The following is a description of a gene set: Transcription regulation during the cell cycle is crucial for ensuring genes are expressed at the right time and in the correct amounts, coordinating key processes like DNA replication, mitosis, and cell division. In our study, Genes whose expression fluctuates during the cell cycle (pVal < 0.05) and peaks in G2/M (G2/M) in K562 Human Gene Set: PULVER_FOREY_CELLCYCLE_PEAKING_G2_M studied in species Homo sapiens, and this is the list of marker genes: RUSC2, KCTD2, CCDC57, CENPA, CYTH3, GAD1, RUVBL2, YIF1B, BRD8, PPP6R2, PYM1, RCOR1, FRAT2, NOL7, BCKDK (NCBI Gene Id 94996), UCKL1, NOB1, DCAF6, GAS2L3, LRRFIP2, PHF21A, MKNK1, MEX3A, USP19, PER1, CD55, EXOC7, NUDT13, AURKA, MAP3K10 (mitogen-activated protein kinase kinase kinase 10), ARRDC1, PPIP5K1, CCDC86, UBAC2, KDM8, CTNND1, PRPSAP1, DDX54, PGLS, FZR1, PCMTD2, FHL3, ENC1, HERC2, FCGR2A, HSPA6, SORT1, ECE2, FBXO31, FAM72B, TNFRSF12A, MYPOP, DPAGT1, TNNT1, GLG1, GALK1, RASA3, TESMIN, FPGS, GPSM2, RPUSD3, ATP8B4, ARVCF, ADGRE5, RXRB, MICALL1, RNF216, WDFY2, MTA1, HSD17B7, ERBB2, PDXK, EPS15L1, CAPN1, CCSAP, CHRNB1, AAR2, RRS1 (NCBI Gene Id 90810), SGPL1, REPIN1, HINT3, NFATC4, D2HGDH, PTPN23, TST, IRF2BPL, ZNF165, DGAT1, RCSD1, LRP10 (NCBI Gene Id 26020), ZMAT1, ATXN2, WEE1, ITPKC, TRIM5, AKR1C1, TGIF2, FAM43A, DLGAP5, UBTF (upstream binding transcription factor), IVD, MPV17L2, ARHGEF11, RAPGEF1, DIP2B, KRI1, TCEANC2, PSMD13, WDR46, THADA, PILRB, TNIK, GRIN2D, C6orf62, ARHGEF7, SLC2A14, UBE2O, FLOT1, AQP10, SIX5, CBX6, TMCO3, SYMPK, SNX9, GPR108 (G protein-coupled receptor 108), CSMD1, CCDC85C, ST7, ANKS1A, PRMT5, RUNX2, PRKD2, TNRC18, DPH2, NUDT2 (NCBI Gene Id 318), KLC2, HSPA1A, NR1D1, PHACTR1, RANGRF, HP1BP3, PHLDB3, KAT2A, PPP1R10, SNX29, GOT1, RANGAP1, SPDL1, PSMD3, MMACHC (NCBI Gene Id 25974), CCDC61, SLC2A3, IFT172, PITPNM1, TNFAIP8L1, TOMM34, CEP164, PEMT, ITGB5 (integrin subunit beta 5), KLF16, ESRRB, CMIP, KNSTRN, MEN1, ZNF783, PAK4, SCAP, HOOK2, NDE1, EEIG1, FAM53B, TMEM19, FAM110A, CSNK1G1, KDM4D, BCAT2, SLC26A2, DNAAF5, PARP3, SPHK2, ANXA7, MOGS, PTRH1, R3HDM4, NUTM2D, SERPINB6, NUDCD2, VSIG10L, AIM2, HDAC7, CBL, TSKS, FCSK, CSNK1E, HSPA1B, SUFU, AGPAT3, KATNA1, PFKFB4, CDC42EP2, PAFAH2, CDIPT, KCNH4, PPARD, CLDN11, NCBP2, TBC1D22A, HAX1, DEPDC1, IFT140, JARID2, RNF169, PSRC1, ACAD10, ALG3, AGAP1, DTX2, INTS3, DDX10, CEP70, MAVS, ZNF593, FTSJ1, PLK1, CTSH, PPFIA3, SGO2, UBL7 (NCBI Gene Id 84993), DHX34, SNAI3, TP53BP1, UBE2R2, CEP44, PDE4A, FAM118A, AIMP2, RPS6KA4 (ribosomal protein S6 kinase A4), FIS1, MRPL4, ERF, NRXN2, GRAMD4, CDYL (chromodomain Y like), FADS1, YTHDC1, MAPKAPK3, USP36, LRWD1, PABPN1, FLNB, ERCC2, IPO13, ZSCAN5A, CD59, TSSC4, MIGA2, CR1, TRIB2, PHF23, TRIM47, UBALD2, ZMIZ2, CKAP5, CLUH, KDM4B, CDAN1, MAN1B1, SOX12, CDK19, DELE1, PPM1H, SLCO2B1, GID4, CDC42BPA, KCNJ8, PPP2R5D, AKIRIN2, MVK, MRPS26, ARHGAP21, TRIM59, ZNF48, VANGL1, ZSCAN2, CCDC120, HERPUD2, SNX1, MICA (MHC class I polypeptide-related sequence A), TRIP6, YDJC (YdjC chitooligosaccharide deacetylase homolog), EMC9, TBX1 (NCBI Gene Id 7413), DCTN1, QTRT1, AGTRAP, FCRLB, MCRIP2, PTGES2, ACTR1A (NCBI Gene Id 10121), AP2A2, RNH1, CNNM2, RAB31, UBE2G1 (ubiquitin conjugating enzyme E2 G1), CACNA1I, NLK, RGP1, PPP1R11, CENPE, MIF4GD, SLC45A4, STON2, TACC3, MVD, NOS3 (NCBI Gene Id 4846), PKN1, PRICKLE3, KDM2A, TRIM4, NEK2, TSC2, ARHGEF39, ITGA5, PWWP3A (NCBI Gene Id 84939), SIGIRR, TMUB2, FBXO6, TEAD2, ZSWIM4, STK17B, ACSS2, EFNA4, PNKD, DNAAF2, KCNH2, CARD8, NACC2, IER5L, HMG20B, ATP8B3, PPP2R5A, KIF4B, WBP2, ANKIB1, DAPK2 (death associated protein kinase 2), MAPKAPK2, SMARCAL1, APOL4, ATG4B, KRT18, PMVK, BRMS1, OTUB1, VASP, HMGB3, RP9, NRROS, SNX33, MAX, KIF14, ERG28, GBA1, ZBTB22, NCAPD2, RAP2B, TNIP1, G6PD, MED12, MITF, C8orf82, PIAS3, KIF4A, FURIN (furin, paired basic amino acid cleaving enzyme), TKFC, NEU1, MID1, IQSEC2, DVL1, FBH1, EIPR1, LMTK3, POLR3H, AMIGO2, JPT1, HSPG2, FOXJ2, AFG1L, NEURL1B, HMMR, COMMD7, FAM3A, RCC1, GTSE1, SETDB2, PTTG1IP, SLC27A4, FZD2, BAZ2A, ADO, MLXIP, SURF4, STIM1, YWHAG (tyrosine 3-monooxygenase/tryptophan 5-monooxygenase activation protein gamma), TANGO6, CLCN5, CCNF, CALM2 (calmodulin 2), PQBP1, CDK2AP2, BCL2L13, POR, CCDC134, G6PC3, TBC1D25, MRTFA (NCBI Gene Id 89880), SAPCD2, EHD1, HIF1AN, PLA2G3, DYNC2I1, FLYWCH1, NABP2, CCNB1, CTBP1, DEXI, NECTIN2, CASP8, RNF5, SMTN, GRK6, ZDHHC18, OPLAH, PKP3, NOA1, RUSF1, MPST, VPS37B, EPHB6, TUBA1C, SOX15, TRIM41, MUC19, SLC39A11, ZNF296, RFX5, HEY1, PIMREG, BRF1, ISYNA1, NARF, LZTR1, RAB4A, AJUBA, ARID5B, ACY1, HNRNPA0, DNM2, UBE2S, MAP2K2, TFE3, PYCR1, B9D1, PTPN9, ZNF3, NECAP2, SHKBP1, DCAF8, SAMD4A, PCGF3, TMEM184B, ANTXR2, SRF, NDST1, RSAD1, ATP2B4, ARL6IP1, INTS15, PRKCB, RFNG, INO80B, PARD3B, POLL (DNA polymerase lambda), SKI, KIF26B, GAK, MAPKAP1, FAM83G, SLC11A1, ANK3, FGF5, POMT2, TRIM27, POLG2, NCOA3, EML3, GRB10, ATF6B, FAM117A, TRAPPC12, SCARB1, SUN2, SIL1, ADD1, LRCH4, STXBP5, COL4A2, RBBP6, LYN, VRK3, RNF19B, HSPBP1, AXL, UNC45A, TRIM8, CKS2, MAF, GEMIN2, BAG3, NOSIP, TMEM161A, RNF10, SLC25A35, ZBTB12, MED13L, IFT122, PLEKHG4, MAEA, CELSR3, LMBR1L, ZNF768, SLC6A6, NICN1, WRNIP1, NAV1, CBX7, TNKS1BP1, CSTPP1 (NCBI Gene Id 79096), FHOD1, SSNA1, KMT5B, ZNF746, ATP7B, DAZAP1, MOB3A, CDC37, DNAAF3, BUB1, KIF13A, HAGH, AGAP3, PCF11, DUSP18, DCTN3, RNF44, CCDC167, TMUB1, MED27, SH2D3C, WNT5B, BACH2, AHDC1, DVL3, KPNA2, ITPR1, STX3, AMBRA1, NOTCH1, RNPEP, PISD, ZNF771, TUBB6, CERK, IGHMBP2, PIF1, ZMYND8, POLR1C, SCLT1, ZNF850, DHPS, HOXB4, PRDM10, CTU1, MFSD12, TLN1, CRTC3, SESN2, WBP1L, NRARP, CDCA8, DPH1, CLIP1, DBF4B, PEF1, B4GALT5, SPTBN1, RPP38, FIBP, CRCP, GALM, E2F5, GDPGP1, MKRN2, CCNB2, IKBIP, TDRKH, UBXN6, RNF26, ZMYM1, ZSCAN29, GIPC3, BIRC5, YIPF2, MIIP, HOXB2, NCK2, FOXK1, ENTR1, MATN1, WRAP53, TRIM65, SLC39A3, ISOC2, TRIB1, IRAK1 (NCBI Gene Id 3654), PAN3, RASSF1, TMBIM1, TFR2, GSS, ASPM, B3GNTL1, KDM4A, EEF2, EZR, RAB40C, PHF7, ENTPD6, ADCY7, MGAT3, PFKFB2, PNPO, CDC25B, RNF43 (ring finger protein 43), SLC24A1, PITPNM2, CSRNP2, ARHGEF2, SPATC1L, DNMT3B, LTBR, SLC25A22, RBM20, SPTBN2, KDM5B, FSCN1 (fascin actin-bundling protein 1), WT1, CR2, HOXB9, METAP1D, ABCA3 (NCBI Gene Id 21), CAB39, SERTAD1, PC, NOP16, IFT46, PCYT2, ANKS3, PBX2, TRABD (NCBI Gene Id 80305), TMEM150B, TRMT10B, REEP4, GGT7, CRADD, TXNDC12, MICAL2, PDE4DIP, ZKSCAN5, HIC2, B4GAT1, POLR3GL, DCAF11, G2E3, TMEM129, GATA1 (NCBI Gene Id 2623), PACC1, ZMIZ1, CHST2, NUDT4, UIMC1, C20orf96, GABBR2, LYL1, KIF20A, DAG1, RERE, ZNF786, MTCL2, ERCC1, KXD1, NAT9 (NCBI Gene Id 26151), GPATCH2L, LCP2, LSG1, TARBP2, STXBP1, AP1G2, ODF2, FDXACB1, CCDC88C, PPME1, TLNRD1, PTDSS2, EXOSC7 (NCBI Gene Id 23016), CCND1, SAFB, NDUFS2, MLLT11, TROAP, CNTROB, MCRS1, DENND5A, PDIA4, SCAND3, LSM10, USE1, LMO7, UNC13D, LIPT2, YPEL1, VPS28, KIF3B (kinesin family member 3B), TRMT61A, LRRC41, ATP6AP1